The following is a description of a gene set: Reactome Pathway: Nuclear Pore Complex (NPC) Disassembly species: Homo sapiens part of: Nuclear Envelope Breakdown Nuclear envelope breakdown in mitosis involves permeabilization of the nuclear envelope through disassembly of the nuclear pore complex (NPC). Nucleoporin NUP98, located at both the cytoplasmic and the nucleoplasmic side of the NPC, and involved in the formation of the transport barrier through its FG (phenylalanine glycine) repeats that protrude into the central cavity of the NPC, is probably the first nucleoporin that dissociates from the NPC at the start of mitotic NPC disassembly. NUP98 dissociation is triggered by phosphorylation. Phosphorylation of NUP98 by CDK1 and NIMA family kinases NEK6 and/or NEK7 is needed for NUP98 dissociation from the NPC. While the phosphorylation of NUP98 by CDK1 and NEK6/7 is likely to occur simultaneously, CDK1 and NEK6/7-mediated phosphorylations are shown as separate events, for clarity purposes., and this is the list of marker genes: RANBP2 (NCBI Gene Id 5903), NUP85, NUP42, TPR, NEK9 (NCBI Gene Id 91754), SEC13, RAE1 (ribonucleic acid export 1), NUP88, NUP133, POM121C, NUP50, NUP54, POM121, NUP160, CCNB1, NEK7, CDK1, NUP214, NUP107, NUP58, NEK6, AAAS, NUP155, NUP98, SEH1L, NUP210, NUP205, CCNB2, NDC1, NUP188, NUP37, NUP62, NUP153, NUP93, NUP43, NUP35